The following is a description of a gene set: Human Gene Set: GSE17721_0.5H_VS_24H_PAM3CSK4_BMDC_DN from publication Amit I, Garber M, Chevrier N, Leite AP, Donner Y, Eisenhaure T, Guttman M, Grenier JK, Li W, Zuk O, Schubert LA, Birditt B, Shay T, Goren A, Zhang X, Smith Z, Deering R, McDonald RC, Cabili M, Bernstein BE, Rinn JL, Meissner A, Root DE, Hacohen N, Regev A (PMID 19729616) Genes down-regulated in comparison of dendritic cells (DC) stimulated with Pam3Csk4 (TLR1/2 agonist) at 0.5 h versus those stimulated at 24 h. species: Homo sapiens mouse primary BMDCs were stimulated with tlr ligands and gene expression changes were profiled on Affymetrix arrays, and this is the list of marker genes: CABLES2, RPL7L1, MRPL57, TMA16, CDH6 (NCBI Gene Id 1004), MTF2, HPS3, WBP2, RAB10, KLHL7, ADAD1, SEC14L1, ACOT7 (acyl-CoA thioesterase 7), PPP1R11, LMBRD1, HSD17B12, NINJ1, ASF1A, TMED5, GDI1, SERF2, FZD3, SIGLEC7, BPNT1, NET1, MPLKIP, ENPP2 (NCBI Gene Id 5168), SASH1, ZSWIM7, PAPSS1, GLYR1, RHOT1 (NCBI Gene Id 55288), TBCE, GPR85, PLA2G2E, TMEM184C, C5, MYOF, CAPZA1, ZNF841, FBXO4, DENND5A, HECTD1, TAX1BP1, SPRYD7 (SPRY domain containing 7), RNF11, PARP8, SMIM14, EEF1E1, CDK2AP1, DYNLRB1, TRPC4AP, TRAPPC13, ARHGAP12, TRMT1L, SLC25A10, TM2D3, EPM2AIP1, HLCS, TXLNB, NUB1, ZDHHC20, CD1D, DCN, CLK4, KCNA3, ABHD17C, CREBZF, GUCA1A, ASH2L, IAH1, DHPS, HADHA (NCBI Gene Id 3030), ITGAV, BET1, GHR, KHDC4, LIF, UBE2W, TCF4, COPB1, RABAC1 (NCBI Gene Id 10567), ANAPC1, AKNA (NCBI Gene Id 80709), USP47, CDC27, CNPY2, PDZRN3 (PDZ domain containing ring finger 3), ATF4, SENP6, PTPN1, SNX18, NEU1, ZC3H11A, ZC3H8, DNAJB6, GSS, ZNF451, AHSA1, CPNE3, CHMP5, ACSL5, CHIC2, HSPA9, LUC7L3, C11orf58, SPATA13, PAICS, PHKB, PLRG1, CNOT8, MDM2, GORASP1, FGF3, BCDIN3D (NCBI Gene Id 144233), STUB1, DAPK1, ITM2B, UBE2B, GGH, ZC3H12A, DOCK5, CYB5R4, RAF1, HIF1A, CCNT1, SCD, ATP5F1E, TTC39C, DCBLD2, DYNLT3, PC, ABCB1, ETFBKMT, TLK2 (tousled like kinase 2), C1S, DBI, NIF3L1, SLAMF9, CISD1, GK, POLA2, EIF1AX, TFPI, MAP3K7, JAG1, VCAM1, LTC4S, GRAMD2B, TM4SF5, RAB24, ODR4, ERGIC2, HSPH1, MAGED1, TK1, WDR13, CD9, SMPD2, CCDC107, CLIP1, JAK1, KLF3, UBE2M, CHAC2, C16orf87, KCTD14, SERINC3, SOCS1, PTPRK, PMPCB, SLC25A17, ALCAM, ABCC3, TNPO2, SEC24D, EPCIP, PATZ1, RDH14, CDKN2AIPNL, CIB1, LCP2, LACTB2, PDE6G (NCBI Gene Id 5148), C18orf32, SLC27A4 (solute carrier family 27 member 4), LRBA, RAMAC, LRRC40, PLCB4, ATP2A2, HDAC2, LAPTM4A, PCBP4, DNAJC28, MAP1LC3B, CSMD1, COMMD6, CPD, NR1H2